The following is a description of a gene set: Human Gene Set: HALLMARK_HEDGEHOG_SIGNALING Genes up-regulated by activation of hedgehog signaling. from publication Liberzon A, Birger C, Thorvaldsdóttir H, Ghandi M, Mesirov JP, Tamayo P (PMID 26771021) studied in species Homo sapiens, and this is the list of marker genes: VEGFA, NKX6-1, GLI1, PLG, NRP1, THY1, ADGRG1, RASA1, TLE3, CRMP1, AMOT, PTCH1, CELSR1 (NCBI Gene Id 9620), SHH, ACHE, CNTFR, TLE1, L1CAM (NCBI Gene Id 4268), NRCAM, UNC5C, OPHN1, SCG2, CDK6, DPYSL2, RTN1, LDB1 (LIM domain binding 1), HEY1, MYH9, ETS2, HEY2, VLDLR, PML, NF1, SLIT1, NRP2, CDK5R1